Given this list of marker genes Pparg, Cebpa, Per2, Prdm16, Pdgfra, Retreg1, Scd1, Fabp4, Creb5, Wfdc21, Id2, Adig, Atf2, Fgf10 (NCBI Gene Id 14165), Ncor2, Sirt1, Ctbp1, Tbl1xr1, Snai2, Npr2, Ctbp2, Ffar4, Zfp423, here is a description of the gene set: species: Mus musculus Mouse Gene Set: GOBP_WHITE_FAT_CELL_DIFFERENTIATION The process in which a relatively unspecialized cell acquires specialized features of a white adipocyte, an animal connective tissue cell involved in energy storage. White adipocytes have cytoplasmic lipids arranged in a unique vacuole.